The following is a description of a gene set: A protein complex that contains an ortholog of the Saccharomyces ATPase Swi2/Snf2 as one of the catalytic subunit components (ATPase) and mediates assembly of nucleosomes, changes to the spacing or structure of nucleosomes, or some combination of those activities in a manner that requires ATP. Mouse Gene Set: GOCC_SWI_SNF_SUPERFAMILY_TYPE_COMPLEX species: Mus musculus, and this is the list of marker genes: Pbrm1, Mybbp1a, Uchl5, Ss18l1, Znhit1, Bcl7b, Actr8, Tfpt, Smarcd3, Ruvbl1, Smarce1, Ddx21, Ruvbl2, Hdac2, Baz1a, Bicral, Cecr2, Hdac1, Smarca2, Smarcc1, Smarcd1, Nfrkb, Smarca5, Smarca4, Rbbp4, Gatad2b, Smarca1, Ino80, Actr5, Dpf3, Brd7, Actl6b, Bcl7a, Mta1, Mbd3, Arid2, Rsf1, Rbbp7, Brd9, Chrac1, Ercc6, Dmap1, Bptf, Actb (actin, beta), Smarcb1, Dpf2, Dek, Ino80e, Ep400, Gatad2a, Mbd2, Luzp1, Smarcc2, Mta3, Myo1c, Kat5, Suz12, Ss18, Pole3, Cdk2ap2, Baz2a, Anp32e, Ino80c, Actr6, Bcl11a, Actl6a, Hmgxb4, 0610010K14Rik, Smarcd2, Trrap, Cfdp1, Srcap, Brd8, Sf3b1, Phf10, Baz1b, Cdk2ap1, Cdk2ap1rt, Dpf1, Mta2, Gon4l, Ing3, Chd3, Mcrs1, Chd5, Bicra, Ino80d, Chd4, Ino80b, Arid1b, Yy1 (YY1 transcription factor), Arid1a, Bcl7c, Bcl11b, Sall1